Given this list of marker genes Esyt1 (extended synaptotagmin-like protein 1), Cln3, Esyt3, Esyt2, Arf1, Plekha8, Gltp, Cptp, here is a description of the gene set: Mouse Gene Set: REACTOME_GLYCOSPHINGOLIPID_TRANSPORT studied in species Mus musculus Glycosphingolipid transport